The following is a description of a gene set: species: Homo sapiens Any process that decreases the rate, frequency or extent of macrophage derived foam cell differentiation. Macrophage derived foam cell differentiation is the process in which a macrophage acquires the specialized features of a foam cell. A foam cell is a type of cell containing lipids in small vacuoles and typically seen in atherosclerotic lesions, as well as other conditions. Human Gene Set: GOBP_NEGATIVE_REGULATION_OF_MACROPHAGE_DERIVED_FOAM_CELL_DIFFERENTIATION, and this is the list of marker genes: PPARA (NCBI Gene Id 84730), ITGB3, NR1H3, NR1H2, MIR130B, ITGAV, ADIPOQ (adiponectin, C1Q and collagen domain containing), CRP (NCBI Gene Id 1401), ABCA5, NFKBIA, ABCA1, CETP, PPARG, ABCG1